The following is a description of a gene set: species: Homo sapiens Genes up-regulated in dendritic cells: wildtype versus NFKB2. from publication Lind EF, Ahonen CL, Wasiuk A, Kosaka Y, Becher B, Bennett KA, Noelle RJ (PMID 18566401) Human Gene Set: GSE7219_WT_VS_NIK_NFKB2_KO_DC_UP This study aims at identifying genes that are NIK/NF-kappaB2 responsive in murine dendritic cells matured in vivo., and this is the list of marker genes: DNAJA4, NAAA, TOP2A, CD86, TLR7, SPRY1, GLRX, DUSP16, NFKBIA, NEDD9, CBX4, XCL1, CLIC4, WNK1, TSC22D2, ISG20, IL6ST, SLC16A10, CCL3, RGS1, ARRDC3, PDE4B, ZNRF1, RNF213, TOB1, TINF2, ZFP1, TNFRSF1B, USP18, SMOX, CXCR6, PDCD1, GLA, CORO2A, MXD1, SIDT2 (NCBI Gene Id 51092), HAVCR2, KLF10, SH2D2A, ABR, STAT1, DHX58, PRNP, CASP3, STAT3, ENTPD1, SMAD7, HSP90AB1, RSAD2, IFNGR1, H2AC25, PERP, KIF11, PTGER4, POFUT2, BAIAP2, JMY, ITK, SLC38A2, TFIP11 (tuftelin interacting protein 11), GZMB, PIK3AP1 (phosphoinositide-3-kinase adaptor protein 1), IFI44, HELZ2, ERN1, CCL4, BRD2, GRINA, CYP51A1, SERTAD2, ETS2, SIPA1L1, EGR1, DUSP2, RNF125, ILDR1, SF1 (splicing factor 1), CEMIP2, ITGA1, HERPUD1, UBE2S, HIF1A (NCBI Gene Id 3091), GEM, CDH1, HSP90AA1, ZFP36, QPCT, LAMC1, TOB2, RHOB, ZFP36L1, ZYG11B, TRAF4, SNX18, NIBAN1, ARID5A, IL21R, JUN (NCBI Gene Id 3725), NUP98, SERPINB9, HMGCR, PLCXD2, PDE4D, HPGDS, ST3GAL3, B4GALNT4, DUSP6, HSPD1, SOCS3, PHLDA1, ARL5B, RAD54L2, NFIL3, CWC25 (NCBI Gene Id 54883), ZCCHC2, CISH (cytokine inducible SH2 containing protein), DGAT1, FNDC3A, FOSL2, GPR34, ZBTB2, CD274, UBE2L6, PNRC1 (NCBI Gene Id 10957), GPR171, NRIP1 (nuclear receptor interacting protein 1), GADD45B, COTL1, EEIG1 (NCBI Gene Id 90676), KDM2B, PDE7A, NMRK1, TRIM36, ITM2C, H2AX, IDI1, TRAFD1, LPXN, DOCK9, MALT1, UBC, RBPJ (recombination signal binding protein for immunoglobulin kappa J region), QSOX1, SKIL, MEX3C, OAS3, TJP1, PTK2B, HSPA1A, FTH1, UBALD1, DNAJB1, SELENON, ATAD2, PMAIP1, ADAM19, ATF3, PRDX6, GOT1, PPP2R1A, IRF7, RRAD, CXCL10, TNF (tumor necrosis factor), CCDC117, FGL2, NKRF, FMNL3, TOX, SLC7A5, BAMBI, LILRB4, TMEM184B, ZBP1, NCOA2, GPR132, TMEM97, PLK3, ST8SIA1, LMNB1, PPP1R15A, IL2RA, AMD1, DNAJB4, SIRT1